Given this list of marker genes Sox9, Hesx1, Eya1, Tcap, Fgf3, Cep290, Fgf10, Tbx1, Fgfr2, Stox1, Fgf8, here is a description of the gene set: species: Mus musculus Mouse Gene Set: GOBP_OTIC_VESICLE_MORPHOGENESIS The process in which the anatomical structures of the otic vesicle are generated and organized. The otic vesicle is a transient embryonic structure formed during development of the vertebrate inner ear.